Given this list of marker genes NAP1L1, LMO2, RBM47, ANAPC16, ATM, HSD17B11, P2RY13, OSBPL8, CD46 (NCBI Gene Id 4272), CMPK1, FIS1, ZNF217, here is a description of the gene set: Human Gene Set: GAUCHER_PBMC_YF_VAX_STAMARIL_UNKNOWN_AGE_14DY_DN studied in species Homo sapiens from publication Gaucher D, Therrien R, Kettaf N, Angermann BR, Boucher G, Filali-Mouhim A, Moser JM, Mehta RS, Drake DR 3rd, Castro E, Akondy R, Rinfret A, Yassine-Diab B, Said EA, Chouikh Y, Cameron MJ, Clum R, Kelvin D, Somogyi R, Greller LD, Balderas RS, Wilkinson P, Pantaleo G, Tartaglia J, Haddad EK, Sékaly RP (PMID 19047440) Correlates of immune-mediated protection to most viral and cancer vaccines are still unknown. This impedes the development of novel vaccines to incurable diseases such as HIV and cancer. In this study, we have used functional genomics and polychromatic flow cytometry to define the signature of the immune response to the yellow fever (YF) vaccine 17D (YF17D) in a cohort of 40 volunteers followed for up to 1 yr after vaccination. We show that immunization with YF17D leads to an integrated immune response that includes several effector arms of innate immunity, including complement, the inflammasome, and interferons, as well as adaptive immunity as shown by an early T cell response followed by a brisk and variable B cell response. Development of these responses is preceded, as demonstrated in three independent vaccination trials and in a novel in vitro system of primary immune responses (modular immune in vitro construct system), by the coordinated up-regulation of transcripts for specific transcription factors, including STAT1, IRF7, and ETS2, which are upstream of the different effector arms of the immune response. These results clearly show that the immune response to a strong vaccine is preceded by coordinated induction of master transcription factors that lead to the development of a broad, polyfunctional, and persistent immune response that integrates all effector cells of the immune system. Genes down-regulated in peripheral blood mononuclear cell 14d vs 0d in unknown after exposure to YF-Vax/Stamaril, time point 14D